Given this list of marker genes TRIM24, ARRB1, MARK3, ITGB3, KRAS, AKAP9, MAP2K1, MPRIP, JAK2, RAF1, VWF, TLN1, AGTRAP, CAMK2G, ATG7, ARAF, CAMK2A, ARRB2, CAMK2D, RAP1A, PEBP1, FN1, CLCN6, KSR1, TENT4A, AGK, LMNA, CNKSR1, FGG, ACTG1, ESRP1, ITGA2B, HRAS, CAMK2B, FAM131B, FGA, QKI, FGB, FXR1, MAPK3, AGGF1, CSK, RAP1B (NCBI Gene Id 5908), FAM114A2, NRAS, ACTB, SRC, CALM1 (calmodulin 1), BRAF, MAPK1, KIAA1549, AP3B1, BCL2L11, KDM7A, PAPSS1, ZC3HAV1, CNKSR2, KSR2, APBB1IP, TRAK1, MAP2K2, VCL, SND1, IQGAP1, YWHAB, here is a description of the gene set: Signaling by BRAF and RAF1 fusions species: Homo sapiens Human Gene Set: REACTOME_SIGNALING_BY_BRAF_AND_RAF1_FUSIONS